Given this list of marker genes Crhbp (NCBI Gene Id 12919), Gnrhr, Mgarp, Akr1c18, Tcf12, Anxa5 (annexin A5), Gpr173, Umodl1, Nr5a1, here is a description of the gene set: studied in species Mus musculus Mouse Gene Set: GOBP_RESPONSE_TO_GONADOTROPIN_RELEASING_HORMONE Any process that results in a change in state or activity of a cell or an organism (in terms of movement, secretion, enzyme production, gene expression, etc.) as a result of a gonadotropin-releasing hormone stimulus. Gonadotropin-releasing hormone (GnRH) is a peptide hormone responsible for the release of follicle-stimulating hormone (FSH) and luteinizing hormone (LH) from the anterior pituitary. GnRH is synthesized and released by the hypothalamus.